Given this list of marker genes Cps1, Acat1, Pklr, Kcna4, Atp1a1 (NCBI Gene Id 229653), Drg1, Kcnj1, Atp4a, Adprh, Atp1a2, Hdac4, Pkm, Pdxk, Kcnj11, here is a description of the gene set: Mouse Gene Set: GOMF_POTASSIUM_ION_BINDING studied in species Mus musculus Binding to a potassium ion (K+).